Given this list of marker genes MRGPRX2, CSPP1, FGF3, OR1A2, CDCA8, CDC6, HTR2B, KIF3B, RACGAP1, FGF5 (fibroblast growth factor 5), ECT2, OPN1MW, TGFB2, RAB11FIP3, EXOC7, TAS1R2, CDC25B, INCENP, TGFB1, BTC, NUP62, WNK1, THBS4, ARF6, GKN1, POLDIP2, ZNF16, EREG, DRD3, GAREM1, SPAST, FGF4, RHOA, FGF8, IL1B, OPN1LW, PTN, CHMP3, VEGFA (vascular endothelial growth factor A), CIT, VEGFD, BIRC5, FGF9, YBX1, PROK1, PGF, AURKB, PDGFB, OR2A4, AURKC, VEGFC, RAB11A, ITGB1BP1, SHH, SIRT2, PDGFD, CDC42, PDGFA, IL1A, CAT, FGF6, PKP4, PPBP, KIF20B, VEGFB, HDGF, MAP10, CDC14B, CDC14C, PDGFC, TAS2R13, MACC1, DRD2, FGF7, TAL1, TGFB3, PRKCE, SVIL, FGF1, FGF2, CENPV, CXCR5, OPN1MW2, CUL3, PKN2, KIF23, SSTR5, LBH, RXFP3, OSM, KIF14, GIPC1, CDC14A, IGF2, NKX3-1, TGFA, MDK, FGFR2, here is a description of the gene set: Any process that activates or increases the frequency, rate or extent of cell division. Human Gene Set: GOBP_POSITIVE_REGULATION_OF_CELL_DIVISION species: Homo sapiens